Given this list of marker genes VGF, NFKBIA, HSPA2, TRPA1, SLC25A27, FOXO1, HSP90AA1, RNF34, UCP1, CIDEA, UCP2 (NCBI Gene Id 7351), THRA, TMEM135, DNAJC3, ADRB2, ACOT11, EIF2AK4, SLC9A1, HSPD1, PLIN1, NFE2L1, SCN11A, PRKACA, ADRB3, LIPA, UCP3, PRKAA1, CDH8, CIRBP, APPL2 (adaptor protein, phosphotyrosine interacting with PH domain and leucine zipper 2), EIF2AK3, METRNL, SLC27A1, ZNF516, TRPM8, SAXO1 (stabilizer of axonemal microtubules 1), LRP11, GMPR, ACADM (NCBI Gene Id 51779), P2RX3, ADRB1, PLAC8, PCSK1N, ACADVL, here is a description of the gene set: studied in species Homo sapiens Any process that results in a change in state or activity of a cell or an organism (in terms of movement, secretion, enzyme production, gene expression, etc.) as a result of a cold stimulus, a temperature stimulus below the optimal temperature for that organism. Human Gene Set: GOBP_RESPONSE_TO_COLD